Given this list of marker genes Hnf1b, Bax, Foxf2, Tyro3 (TYRO3 protein tyrosine kinase 3), Mertk, Sox2, Fgf10, Lrp6, Wnt9b, Lrp2, Trp63, Tcf7l2, Nipbl, Pdgfra, Chd7 (chromodomain helicase DNA binding protein 7), Dnajc19-ps, Cyp19a1, Bmp5, Fgf8, Ror2, Wt1, Hoxa13, Axl, Esr1, Bak1, Npr2, Asb1, Neurog1, Hoxd13, Tifab, Srd5a2, Ptpn11, Klhl10, Tbx3, Nkx3-1, Greb1l, Ar (androgen receptor), Tex15, Lhx1, Dnajc19, Lgr4, Tcf7, Esr2, Ctnnb1, Rbp4, Bmp6, Pkd1, Shh, Dhcr24, Wnt5a, Stra6, Sycp2, here is a description of the gene set: Mouse Gene Set: GOBP_GENITALIA_DEVELOPMENT studied in species Mus musculus The process whose specific outcome is the progression of the genitalia over time, from its formation to the mature structure.